Given this list of marker genes NIN, CEP83, CEP164, CENPF, CEP89, DZIP1, SCLT1, FBF1, here is a description of the gene set: Human Gene Set: GOCC_CILIARY_TRANSITION_FIBER species: Homo sapiens A nine-bladed, propeller-like protein complex that links the distal end of the basal body and the cilium to the plasma membrane. Functions in protein sorting and gating (i.e. active and passive transport of proteins in and out of the cilium).